The following is a description of a gene set: Human Gene Set: GOCC_L_TYPE_VOLTAGE_GATED_CALCIUM_CHANNEL_COMPLEX A type of voltage-dependent calcium channel responsible for excitation-contraction coupling of skeletal, smooth, and cardiac muscle. 'L' stands for 'long-lasting' referring to the length of activation. studied in species Homo sapiens, and this is the list of marker genes: CACNG1, CACNB1, CACNG6, CACNA1C, CACNB2, CACNB3, CACNA1S, CACNG4, CACNA1D, CACNG8, CACNG7, CACNA2D1